Given this list of marker genes Gm34276, Rpl17-ps6, Secisbp2, Gm35733, Gm2645, Gm22960, Ippk (inositol 1,3,4,5,6-pentakisphosphate 2-kinase), Jarid2, Dek, Iars1, Ecm2, Gm10113, Ogn, Fgd3, 4930453C13Rik, Gadd45g, Gm2654, Nup153, Dtnbp1, Atxn1, 4930471G24Rik, Gm8672, 1700029N11Rik, Gm10784, Gm25394, 4930518P08Rik, Gm22806, Spata31e1, Tes3-ps, Gm23104, Gm23482, Gm270, Gm7251, Gm8588 (predicted gene 8588), Card19, Aspn, Wnk2, Rnf144b, Sema4d, Gm36550, Fam120a, Gm8674, 4933433N18Rik, Cks2, Gm6056, Gm26651, Kif13a, Gm19334, Cap2, Id4, Mir683-1, Gm272, Cenpp, G630093K05Rik, Mirlet7d, Gm48199, 5033430I15Rik, A830005F24Rik, Gm47792, Nutm2, Phf2, Hsp25-ps1, Gm18807, 2010001K21Rik, Stmnd1, LOC667541, Bicd2, Nol8, Gm49291, S1pr3, Gm29787, Gm19011, Shc3, Ptpdc1, 4921525O09Rik, Fam8a1, Spata31e4, 6720427I07Rik, Gm34466, 4931429P17Rik, Phf2os1 (PHD finger protein 2, opposite strand 1), Gm8700, A330048O09Rik, Gm20789, Gm47412, Mirlet7a-1, Tpmt, Syk, Gm6554, BB123696, Fbxw17 (F-box and WD-40 domain protein 17), H2af-ps2, Mirlet7f-1, Gm32834, Gm40932, Gm8739, Nxnl2, Gm45949, Diras2, 1700026N04Rik, Gm19663, Gm8513, Omd, Spin1, Gm35110, Barx1, Zfp169, Ninj1, Nhlrc1, Gm19009, Rbm24, Susd3, Gm24620, Gmpr, Spata31e3, Gm36101, A930002C04Rik, Gm31126, Gm5790, Mylip, Kdm1b, here is a description of the gene set: studied in species Mus musculus Mouse Gene Set: chr13A5